The following is a description of a gene set: Mouse Gene Set: REACTOME_ASSEMBLY_OF_COLLAGEN_FIBRILS_AND_OTHER_MULTIMERIC_STRUCTURES studied in species Mus musculus Assembly of collagen fibrils and other multimeric structures, and this is the list of marker genes: Col4a4, Col4a5, Col1a1, Col2a1, Loxl1, Col9a2, Col14a1, Tll2, Mmp7, Col4a3, Col4a6, Col3a1, BC051665, Pcolce, Mmp9, Col5a2 (NCBI Gene Id 73740), Col4a1, Bmp1, Col12a1, Col5a3, Mmp13, Col6a3, Col6a2, Ctsl, Col6a1, Col7a1, Col6a6, Loxl2, Loxl4, Col8a2 (NCBI Gene Id 329941), Col10a1, Col4a2, Col9a3, Tll1, Col18a1, Mmp20, Lox, Col15a1, Pxdn, Col11a1, Loxl3, Col8a1, Col1a2, Col11a2, Ctsb, Ctss, Col9a1, Col6a5, Col5a1, Mmp3